The following is a description of a gene set: The establishment, maintenance and elaboration of a pattern along a line or around a point. species: Mus musculus Mouse Gene Set: GOBP_AXIS_SPECIFICATION, and this is the list of marker genes: Notch2, Wls, Fgf10, Wnt6, Fzd5, Nrarp, Aurka, Mesp1, Cdx1, Hey2, Bcor, Epb41l5, Pgap1, Tdrkh, Pcsk6, Tcf7l1, Wdr77 (NCBI Gene Id 97079), Tasor, Foxa2, Cdx4, Ift25, Mesp2, Cited2, Lefty2, Nckap1, Setdb2, Six2, Tifab, Pax6, Tdrd7, Hey1, Frs2, Gpc3, Ripply2, Tdrd6, Wnt1, Hhex, C2cd3, Ski, Smad4, Wt1, Ctnnb1, Wnt5a, Kdm6a, Tbx6, Vax2, Smo, Ptch1, Ripply1, Pld6, Tdrd5, Tmed2, Wnt3, Chrdl1, Lrp6, Ddit3, Wnt8a, Ldb1, Notch1, Prickle1, Neurog1, Cer1, Pitx2, Sfrp1, Cited1, Bmp4, Srf (serum response factor), Lhx1, Apc, Pkd1l1, Six3, Stil, Senp2, Wnt7a, Mdfi, Smad6, Tbx3, Zic3, Tdrd1, Irx4, Lefty1, Peg12, Dll1, Rnf2, Axin2 (NCBI Gene Id 12006), Chrd, Smad2, Mns1, Ift172, Bmpr1a (bone morphogenetic protein receptor, type 1A), Gdf3, Otx2, Axin1, Cripto, Ttc8, Tbx18 (T-box18), Nodal, Ets2, Cdx2, Arl13b, Stc1, Frat1, Cobl, Shh